Given this list of marker genes Hdx, Zfp280d (NCBI Gene Id 260391), Jakmip3, Tectb, Ccdc88a, Dock11, Tcf4, Adgrb3, Plch1, Serp2, Rrp1, Bltp3a, Rdh14, Ddx1, Camsap2, Sult1a1, Clcf1, Sox6, Fmn2, Cdh22, Nap1l3, Homer2, Adam24, Chdh, Kcnq5, Pde1c, Ets1, Bcl11b, Colec11, Lats2, Fpgt, Atp2b2, Antxr2, Ctbp2, Pip4p2, Dhx40, Col24a1, Bach2, Tob2, Nampt, C2cd2, Fgf6, Rai14, Ctsa, Vangl1, Cnksr3, Washc4, Usp12, Arhgap9, Sertad3, Akap13, Bicd2, Plxna2, Nr4a3, Pcdh17, Rufy2, Rilpl2, Ccdc117, Npc1, Zdhhc21, Kctd15, Meox2, Chfr, Trappc13 (NCBI Gene Id 69905), Mlxip, Frk, Rbbp5, Tnrc6b, Lrrtm1, Cnpy1, Cbx6, Kbtbd4 (NCBI Gene Id 67136), Tspan9, Ccdc177, Eml1, Hoxb2, Bmp2 (bone morphogenetic protein 2), Camkk2, Zzef1, Fam204a, Rap2a (RAS related protein 2a), Nadk, Sox12, Asxl2 (NCBI Gene Id 75302), Creld1, Robo2, Gcsam, Slc30a5, Pcbp2, Slc7a1, Dmxl2, Wdhd1 (WD repeat and HMG-box DNA binding protein 1), Mre11a, Mtcp1 (mature T cell proliferation 1), Stac2, Ostm1, Zfp108, B3galt1 (NCBI Gene Id 70755), Zfp114, Hlcs, Stk4, Mplkip, Rab11fip2, Btc, Vav3 (vav 3 oncogene), Tmem121, Nme6, Vps28, Ccnc, Ipmk, Mfsd1, Mcrip1, Fah, Zfp384, Micos10, Reln, Mplkipl1, Pramel39-ps, Ct55, Gria4, Plxna4, Gpr101, Bnc1, Ubn2, Ano3, Snd1, Ibsp, Vgll3, Lyn, Enpp6, here is a description of the gene set: studied in species Mus musculus Genes predicted to be targets of miRBase v22 microRNA mmu_miR_378a_5p in miRDB v6.0 with MirTarget v4 prediction scores > 80 (high confidence targets). from publication Chen Y, Wang X (PMID 31504780) Mouse Gene Set: MIR_378A_5P